The following is a description of a gene set: Vitamins are essential nutrients, required in small amounts from the diet for the normal growth and development of a multicellular organism. Where there is vitamin deficiency, either by poor diet or a defect in metabolic conversion, diseases called Avitaminoses occur. Currently, cobalamin (Cbl, vitamin B12) metabolic defects are described below (Chapter 155 in The Metabolic and Molecular Bases of Inherited Disease, 8th ed, Scriver et al. 2001) species: Homo sapiens part of: Diseases of metabolism Reactome Pathway: Defects in vitamin and cofactor metabolism, and this is the list of marker genes: PC, TCN2, MCCC2, MMACHC, ABCD4, BTD, MMADHC, AMN, LMBRD1, MMUT, PCCB, MCCC1, ACACA, CBLIF, PCCA, MMAA, CD320, MTR, CUBN, HLCS, MMAB (NCBI Gene Id 89909), MTRR